The following is a description of a gene set: from publication Cui A, Huang T, Li S, Ma A, Pérez JL, Sander C, Keskin DB, Wu CJ, Fraenkel E, Hacohen N (PMID 38057668) Genes positively differentially expressed in cell type: NK cell upon treatment with cytokine: IFN-κ in mouse lymph nodes in vivo. Mouse Gene Set: CUI_NK_CELL_IFNK_RESPONSE_UP Cytokines mediate cell-cell communication in the immune system and represent important therapeutic targets. A myriad of studies have highlighted their central role in immune function, yet we lack a global view of the cellular responses of each immune cell type to each cytokine. To address this gap, the authors created the Immune Dictionary, a compendium of single-cell transcriptomic profiles of more than 17 immune cell types in response to each of 86 cytokines (>1,400 cytokine-cell type combinations) in mouse lymph nodes in vivo. A cytokine-centric view of the dictionary revealed that most cytokines induce highly cell-type-specific responses. For example, the inflammatory cytokine interleukin-1β induces distinct gene programmes in almost every cell type. A cell-type-centric view of the dictionary identified more than 66 cytokine-driven cellular polarization states across immune cell types, including previously uncharacterized states such as an interleukin-18-induced polyfunctional natural killer cell state. studied in species Mus musculus, and this is the list of marker genes: Helz2, Eif2s2, Magohb, Ppan, Srsf6, Socs1, Pus7, Ranbp1, Srm (spermidine synthase), Sh3glb1, Usp25, Prag1, Isg20, Cacybp, Mrpl19, Actg1, Saysd1, Oas3, Bst2, Eif5a, Ptges3, Trmt11, Snx3 (NCBI Gene Id 54198), Ppp1r14b, Sfxn1, Rpf2, Umps, Snrpb, Ifi213, Anp32b, Trim30a (NCBI Gene Id 20128), Utp18, Ehd4, Nolc1, Isg15, Supt5, Pim2, Nop58, Tuba1c, Hspa8 (heat shock protein 8), Cotl1, Mapkapk2, Pa2g4 (NCBI Gene Id 18813), Irf7, Mettl1, Ppa1, Il2rb, Ifit1, Eif2ak2, C1qbp, Gadd45g, Dtx3l, Bzw1, Gspt1, Rsad2, Rbm3, Ssbp1, Nedd9, Jaml, Rtp4, Psme1, Ifi35, Calm1, Lyar, Txnl4a, Prf1, Ccdc86, U2af1 (U2 small nuclear ribonucleoprotein auxiliary factor (U2AF) 1), Dimt1, Daxx, Cct3, Ifih1 (interferon induced with helicase C domain 1), Plscr1, Atl3 (NCBI Gene Id 77020), Eif4a1, Xbp1, Adprs, Stat1, Metrnl, Cpsf2, Ifi209, Agpat3, Lgals3bp, Serpina3g, Ddx21 (NCBI Gene Id 56200), Osm, Srsf7, Tubb4b, Nlrc5, Eef1e1, Noc2l, Kdm6b, Seh1l, Mat2a, Ncl, Slfn8, Hspa5, Nufip1, Ms4a4b, Wdr43, Irf8, Ogfr, Mitd1, Dkc1, Hnrnpf, Hspd1, Rer1 (NCBI Gene Id 76102), Nhp2, Polr2h, Strap, Slc16a6, Timm8a1 (translocase of inner mitochondrial membrane 8A1), B3gat3, Vasp, Ifi203, Stip1, Usp18, Fbl, Tcof1, H2-T23, Pfn1, Pdcd11, Mndal, Rars1, Timm10, Etv3, G3bp1, Slc7a1, Trim25, Nme1, Ergic2, Cxcl10, Snu13, Ran, Gzmb, Gnl3, Ifi47, Psmb10, Cmpk1, Phf11b, Chd1, Riok1, Zbp1, Slamf7, Tmed5, Pim3, Cycs, Rrs1, Cish, Hspa4, Wdr46, Eif2s1, Xaf1, Bysl, Coro1a, Snrpa1, Parp9, Ifit3, Cd47, Nifk, Hsp90ab1, Ifi204, Fkbp1a, Ccnd2, Cd52, Timm9, Snrpd1, Etf1, Rrp9, Coro2a, Tmem37, Ncr1, Tpm4, Fubp1, Mnt, Trim30d, Pno1, Ddx24, Prkcq, Eif1a, Herc6, Rnf213, Mvb12a, Alkbh1, Mphosph10, Ube2n, Ifi206